Given this list of marker genes Klf2, Btg2, Pnrc1, Ier2, Jun, Dusp1, Nr4a1, Junb, Fos, Klf6, here is a description of the gene set: species: Mus musculus Mouse Gene Set: CUI_T_CELL_GD_C5A_RESPONSE_DN Genes negatively differentially expressed in cell type: γδ T cell upon treatment with cytokine: C5a in mouse lymph nodes in vivo. Cytokines mediate cell-cell communication in the immune system and represent important therapeutic targets. A myriad of studies have highlighted their central role in immune function, yet we lack a global view of the cellular responses of each immune cell type to each cytokine. To address this gap, the authors created the Immune Dictionary, a compendium of single-cell transcriptomic profiles of more than 17 immune cell types in response to each of 86 cytokines (>1,400 cytokine-cell type combinations) in mouse lymph nodes in vivo. A cytokine-centric view of the dictionary revealed that most cytokines induce highly cell-type-specific responses. For example, the inflammatory cytokine interleukin-1β induces distinct gene programmes in almost every cell type. A cell-type-centric view of the dictionary identified more than 66 cytokine-driven cellular polarization states across immune cell types, including previously uncharacterized states such as an interleukin-18-induced polyfunctional natural killer cell state. from publication Cui A, Huang T, Li S, Ma A, Pérez JL, Sander C, Keskin DB, Wu CJ, Fraenkel E, Hacohen N (PMID 38057668)